The following is a description of a gene set: species: Homo sapiens Human Gene Set: GOBP_REGULATION_OF_MACROAUTOPHAGY Any process that modulates the frequency, rate or extent of macroautophagy., and this is the list of marker genes: LRSAM1, PRKAA2, BNIP3L, EHMT2, LRRK2, MAPK8, MTMR8, USP36, CDK5R1, UBE2A, CLEC16A, UBQLN2, ATP6V0E2, SLC25A5, ATP6V1B1, TOMM7, NPC1, PHF23, SIRT1, PAFAH1B2, OPTN, POLDIP2, ATP6V1H, SH3GLB1, WDR45, IL4, HTRA2, GNAI3, HUWE1, ATP6V1E1, TRIM13, EXOC4, WAC, PIK3C3, CERS1, TSC2, RIPK2, ATP6V0A2, SCOC, TOM1, GAPDH, CTTN, NUPR1, ZDHHC19, PIP4K2A, ATP6V1G1, CASP3, SPTLC1, ATP6V0D2, TSC1, VPS13D, PIK3R4, FBXW7, IRGM, ATP13A2, TMEM39A, PINK1, PPTC7, ATP6V1E2, HDAC6, PIM2, MOAP1, UBQLN4, PRKN, HMOX1, RUBCN, RALB, SREBF1, ATP6V1B2, SEC22B, KDR, IKBKG, MUL1, CDK5RAP3, FYCO1, ATG5, CSNK2A1, EIF2AK1 (NCBI Gene Id 27102), MTM1, EXOC7, RAB3GAP2, NAT8B, ATP5IF1, SPTLC2, ATP6V0E1, CSNK2A2, MAP3K7, DNM1L, EXOC8, ELAPOR1, TECPR1, VPS26B, ULK1, ATP6V1G2, LACRT (lacritin), CLN3, CAPNS1, AKT1, NRBP2, RNF31, ADRB2, SNX18, QSOX1, ATG12, MAPK3, FZD5, SNX6 (NCBI Gene Id 58533), BECN1, CALCOCO2, ATG2A, PARL, LZTS1, SNX30, SESN2, SLC25A4, DELE1, SESN1, SESN3, ATP6V1A, RBX1, ADCY10, TRIM32 (NCBI Gene Id 3971), SNX4, ATP6V0A1, NOD1, RNF41, BNIP3, NOD2, HTT, GBA1, HK2, PIP4K2C, NEDD4, FEZ1, CAPN1, STING1, GPSM1, FKBP8, UFL1, HIF1A, RUFY4, FBXO7, LYPLA1, SCFD1, BAG3, FEZ2, ATG14, WIPI1, ATP6V0D1, EPM2A, C9orf72, ERN1, ATP6V0B, VPS13C, PIP4K2B, CDK5, UVRAG, GSK3A, PRKACA, CDC37, HSPB8, FBXL4, RAB3GAP1, TIGAR, SMCR8, MTOR, TP53, LARP1, VDAC1, EXOC1 (exocyst complex component 1), ATP6V1C2, PIK3CA, ATP6V1D, DDRGK1, VPS35, WDR24, TBC1D25, VPS26A, RHEB, SUPT5H, TBK1, USP30, STUB1, AMBRA1, SNX7, SREBF2, ATP6V0C, TSPO, DCN, UBQLN1, KAT5, ATP6V1C1, UCHL1, SNX5, SNX32